Given this list of marker genes PDCD1, SMAD4, BRCA1 (NCBI Gene Id 672), PALLD, RABL3, PALB2, PI4KA, CDKN2A, KRAS, TTC7A, TP53, BRCA2, here is a description of the gene set: The presence of an abscess of the peritoneum. Peritoneal abscess species: Homo sapiens Human Gene Set: HP_PERITONEAL_ABSCESS